The following is a description of a gene set: species: Homo sapiens Any process that results in a change in state or activity of a cell or an organism (in terms of movement, secretion, enzyme production, gene expression, etc.) as a result of an axon injury stimulus. Human Gene Set: GOBP_RESPONSE_TO_AXON_INJURY, and this is the list of marker genes: BAX, CDK1, NEO1 (neogenin 1), MIR222, DHFR, MAP1B (NCBI Gene Id 4131), ADAM17, FLRT3, CNTF, DHFRP1, TYROBP, EPO, JAK2, P2RY12, MAPK8IP3, FIGNL2, KREMEN1, NEFL, RTN4RL2, SLC1A1, KIAA0319, DRD2, RTN4R, MIR34A, GIPR, PTN, JUN, RGMA, MIR221, BCL2, NTRK1, SOD2, BRAF, NREP, RTCA, KLF4, CERS2, FOLR1, EPHA4, PUM2, ARF4 (ADP ribosylation factor 4), PTPRS (NCBI Gene Id 5802), TNC, TREM2, MTR, TSPO, MIR431, ISL1, DAG1, SPP1, TNR, LYN, NPPC, APOD, GRN, SARM1, INPP5F, KCNB1, NTRK3, RANGAP1, LAMB2, MAG, MMP2, MORN4, SCARF1, PTPRF, CTNNA1, MATN2, RTN4RL1, STK24, FGF2, DPYSL3, MAP2K2, P2RX4, NDP, SOD1, BNIP3, LRIG2 (NCBI Gene Id 9860), APOA4, UCK2, PLCG2, MAP2K1, KCNK2, GAP43